The following is a description of a gene set: An abnormal gyral pattern characterized by abnormalities of sulcal depth or orientation. Dysgyria studied in species Homo sapiens Human Gene Set: HP_DYSGYRIA, and this is the list of marker genes: MED11, TUBA1A, TUBB3, PAFAH1B1, LAMB1 (laminin subunit beta 1), ACTA2, TUBB2B